Given this list of marker genes PSG1, ARID4A, PATZ1, ATG16L2, NT5DC3, FRMPD3 (NCBI Gene Id 84443), DYDC2, NPY1R, IKZF3, CHP1, STX5 (syntaxin 5), SNAPC3, SEMA4G, MAP4K1, FAM117B, SKIL, DDX6, JAZF1, SDC3, CCT4, NIPSNAP3B, SLC16A1, SYP, PPP2R5C, ZBTB20 (NCBI Gene Id 26137), ST6GALNAC5, MAML1, CDK15, FAM117A, GASK1A, STK4, CDK8, STK17B, MAPK10, SF3A3, MEPCE, PPDPFL, TRIM32, METTL8, FABP4, SLC1A2, RLIM, TPM1, PALS2, DAB2, DUSP19, URM1, RPS6KA2, SLC36A2, PLBD2, GRIN3A, SYT14, CTNND1, ELK1, MXRA5, PGPEP1, KRT222, PPME1, PELI1, CELF3, CARHSP1, NIPSNAP3A, C1orf105, MYEOV, DMP1, IMPG2, EIF4E3, EBAG9, BCL9, GIGYF1, TSPAN12, SNX20, HNRNPL, RBM19, PLXNA2, GAGE1, HIP1, MARCKSL1, PAK1, GNGT2, IFT140, LURAP1L, GAGE12D, LOX, CORO1C, PYGO1, ZCCHC14, GPATCH2, HYCC1, HS6ST2, ARHGAP9, GCC1, SHOX, TSHZ3, RAB6D, MTCH2, TMT1B, TIMM21, ORAI2, GABBR1, SHISA7, FAM199X, PRR23C, VGLL3, RAB6C, CLIC5, ADAM30, PRSS27, CA6, MAN2A1, ENTPD7, MKKS, SRRM4, NAMPT, BAZ2A, AAK1, AKAP6, ATP1B4, SUCLA2, SLC39A8, TSPYL4, COL4A2, APOBEC3F, UBE3A, PSG4, ABCC4, SYT6, CREM, KCNB1, RASSF8 (NCBI Gene Id 11228), MPPED2, CCL28, IARS1, MDGA2, SSR2, NSMCE3, ZNF275, NAV1, here is a description of the gene set: Genes predicted to be targets of miRBase v22 microRNA hsa-miR-30c-2-3p in miRDB v6.0 with MirTarget v4 prediction scores > 80 (high confidence targets). species: Homo sapiens from publication Chen Y, Wang X (PMID 31504780) Human Gene Set: MIR30C_2_3P